Given this list of marker genes POLD1, RFC2 (NCBI Gene Id 5982), POLE4, POLD3, POLD4, RFC4, RFC1, LIG1, POLE2, POLE, PCNA, POLE3, FEN1, RFC5, RPA3, RPA1, POLD2, RPA2, POLB, APEX1, RFC3, here is a description of the gene set: studied in species Homo sapiens Human Gene Set: REACTOME_PCNA_DEPENDENT_LONG_PATCH_BASE_EXCISION_REPAIR PCNA-Dependent Long Patch Base Excision Repair